Given this list of marker genes RNU6-865P, ABI3BP, DUSP12P1, RNY1P12 (RNY1 pseudogene 12), ENSG00000295040, RPS18P5, ENSG00000275108, RNU6-461P, RNU6-1263P, ARB2BP, NXPE3, ZNF90P1, CMSS1 (NCBI Gene Id 84319), TOMM70 (NCBI Gene Id 9868), TBC1D23, NIT2, FILIP1L, TRMT10C, TMEM45A, ACTG1P13, TMEM30CP, CEP97, RPL32P7, NFKBIZ, PDLIM1P4, ABRAXAS1P1, COL8A1, MIR3921, RNU6-1256P, ARHGEF28P1, RPL24, SENP7, IMPG2, RDUR, TFG, RNU6-26P, ZBTB11, ST3GAL6-AS1, ST3GAL6 (NCBI Gene Id 10402), DCBLD2, ZPLD1, ENSG00000293268, PDCL3P4, BTF3P16, LINC00973, FAM136CP, RPL19P7, LNP1, GMFBP1, ADGRG7, VTI1BP1, PCNP, ACTR3P3, WWP1P1, ZBTB11-AS1, ENSG00000307157, here is a description of the gene set: Human Gene Set: chr3q12 species: Homo sapiens